The following is a description of a gene set: Type I Interferons encompasses a large family of closely related cytokines comprising of at least 13 IFN-α isotypes and single IFN-β. Both IFN-α and IFN-β exert their activity through a common receptor IFNAR. Type I Interferons have broad regulatory effects and various subtypes of dendritic cells are influenced by this cytokines. In our study we asked question whether the low, constitutive levels of type I Interferons produced under steady state conditions are important for proper function of splenic conventional dendritic cells. Human Gene Set: GSE12392_IFNAR_KO_VS_IFNB_KO_CD8_NEG_SPLEEN_DC_DN studied in species Homo sapiens from publication Zietara N, Łyszkiewicz M, Gekara N, Puchałka J, Dos Santos VA, Hunt CR, Pandita TK, Lienenklaus S, Weiss S (PMID 19581626) Genes down-regulated in CD8A- splenic dendritic cells: IFNAR1 knockout versus IFNB1 knockout., and this is the list of marker genes: MRC1, PAWR, BGN, NDST1, RNASE1, MAPK8, GRIN2B, ELOVL5, CXCL3, LIFR, NEUROD4, HMGCS2, MPO, CST8, SMARCAD1, NFKBIA, BATF, ACTR3, ANXA2, ORM1, HIVEP2, ETFB, MCM4, CD93, NR4A1, ZG16, SORBS1, FOXN3, GNRHR, IL1R2, PTPN22, H1-1, SRSF6, CYP1B1, SIT1, EIF4ENIF1, DAGLB, CTPS1, FLII, NOTCH4, SH2D1B, SELPLG, GHRL, RAP2B, SEC61A1, STK40, MADCAM1, CSF3, ACOT2, CYTH2, PCDHA13, ID3, ADAMDEC1, MT1E, SMS, REG3G, PNMT, MYCL, NFKBIZ (NFKB inhibitor zeta), STK10, SMPDL3A, CMTM6, RGS3, PTPA, CEBPZ, PNPO, INPP5D, CLU, PABPC4, TMC6, MMP8, CYTH1, IL6, PPP1R2P1, RDH11, CASK, AREG, C5, CD80, C12orf43, WASHC2A, FPGS, REG3A, HCN3, SCT, EMP1, CTRB2, DMBT1, KRTDAP, PIM2, PLAUR, SS18L2, EZR, CXCL2, CLPS, TRIO, LMNB1, CDC6, ITPKB, OVGP1, TAL2, RHD, GATM, ELANE, PATJ, RABEPK, ADAMTS1, EPS8, ODC1, AMY2A, NDEL1, FGFR3 (NCBI Gene Id 55546), BASP1, MAPK6 (mitogen-activated protein kinase 6), TIE1, REG1A, STK24, MAPRE1, HFE, VPS37B, PTPRE, SRGN (serglycin), HOPX, CARHSP1, LAPTM5, ELF3, HGFAC, SIPA1L2, INPP5A, NIPSNAP1, CDT1, CFHR2, MIDN, ACE, ZFAND2A, SRP9, DUSP16, SOCS3, ERGIC1, RRAD, SFR1, SLC25A20, CETN1, THBS3, NFKB1, NAPSA, DIAPH1, ARL2BP, ACAA2, NDUFB2, PRPS1, UGCG, CELA2A, PTPN23, RRS1, TNIP1, FOSB, HMGB3, ATP1A1, ADORA2B, NOCT (NCBI Gene Id 25819), CDC42EP4, MSH5, RPS6KB1, CEL, NHERF1, ERRFI1, THBS1, SLC7A5, IL4R, CD19, EHD1, REG1B, DUSP2, ELL2, CCRL2, RGCC, BCL2L11, POLR1A, NAB1, SYK, ST3GAL6, LMNA, CYTIP, GPX3, RASIP1, FMNL1, ETF1, HLA-DMB, SVIL, ASL (argininosuccinate lyase), RALB, DDR1, PLD4, PXN, G0S2, PLK2, SPTBN1, TUBA1C, FAM110A (NCBI Gene Id 83541)